Given this list of marker genes NPY2R, SCTR, NPY1R, GABRA5, CX3CR1 (C-X3-C motif chemokine receptor 1), GPR65 (G protein-coupled receptor 65), HCAR3, C3, GRM3, PTGER2, CXCL13, RIN1, ADRA2B, CCL3, FZD2, FPR1, GRM2 (NCBI Gene Id 2912), ACKR1, ADRA2A, PTGFR, DEFB4A, ADRB2, GRIN1, HCRTR1, BDKRB1, MS4A2, ECEL1, ADGRL1, FPR2, GIT2, CCR3, LANCL1, BDKRB2 (bradykinin receptor B2), PRKD3, SCG5, P2RY14, ADORA1, TSHB, GPR171, DGKI, OPRK1, NMU, DRD3, GNAO1, FZD9, PTGER1, PTPN6, CXCL1, CCR8, ADCYAP1R1, GPR17, OR2F1, HCRTR2, P2RY10, RGR, ADORA2A, AVPR1A, RGS5, ADGRE1, RGS3, CCL23, GCG, PLCB2, GNA14, CXCL12, CHRM1, PTGER3, GRM8, GPR75, CCL17 (NCBI Gene Id 6361), GABRA6, CXCL8, RGS16, CXCR4, GAP43, LPAR6, PNOC, CXCR6, ADGRB3, GRB7, CCR2, NTSR1, CORT, TACR3, EDNRA, GHRHR, GNAI1, CXCL2, ADGRL2, DGKA, CXCL9, OR10H3, NPY, GRP, EDNRB, CXCR5, GRB14, PRB4, GPR182, UCN, GPR39, C5AR1, CCR5, GPR183, DEFB1, RGS4, GNAL, GRK5, GPR37L1, GNA15, GABRA2, GABRG2, S1PR4, GRIK1, GRK1, PTAFR, GALR3, CCR1, EDN2 (endothelin 2), C3AR1, AGRP, AKAP12, GNA13, PDYN, here is a description of the gene set: Human Gene Set: MODULE_289 studied in species Homo sapiens Genes in the cancer module 289.